The following is a description of a gene set: SCF(Skp2)-mediated degradation of p27/p21 Human Gene Set: REACTOME_SCF_SKP2_MEDIATED_DEGRADATION_OF_P27_P21 species: Homo sapiens, and this is the list of marker genes: PSMC1, PSMD12, PSMC2, PSMA5, PSMC6, UBC, PSMA2, PSMA7, CCNA1, CCNE1, PSMD1, PSMB4, PSMC4, CCNA2 (cyclin A2), PSMD3, SKP2, UBB, PSMB2, PSMD14, PSMC3, CUL1, PSMA6, SEM1, PSMB1, PSMD8, PSMB6, PSMC5, PSMB5, CCND1, CDK2, PSMD2, SKP1, CDK4, PSMB7, PSMA3, PTK6, PSMD7, PSMA1, CCNE2, CDKN1B, UBA52, ADRM1, PSMA4, PSMD13, CDKN1A, PSMB3, RPS27A (ribosomal protein S27a), PSMD6, PSMD11 (NCBI Gene Id 5717), CKS1B